The following is a description of a gene set: A process that is carried out at the cellular level which results in the assembly, arrangement of constituent parts, or disassembly of a prolongation or process extending from a neuron, e.g. an axon, or a dendrite. Mouse Gene Set: GOBP_NEURON_PROJECTION_ORGANIZATION studied in species Mus musculus, and this is the list of marker genes: Fcgr2b, Lzts3, Dlg4, Marcks, Grin1, Epha4, Tiam1, Ckap5, Ube3a, Septin7, Caprin1, Cntnap2, Homer1, Xlr4b, Dtnbp1, Arc, Psen1, Cdc42 (NCBI Gene Id 12540), Fyn, Opa1, Epha5, Zdhhc15, Itpka, Ppp1r9a, Chrna7, Igf1r (insulin-like growth factor I receptor), Nlgn3, Tanc1, Map1a (NCBI Gene Id 99114), Abcd2, Dbn1, Ppfia2, Pafah1b1, Mtmr2, Dock10, Lrrk2, Eef2k, Dhx36, Dnm1l, Mfn2, Camk2b, Reln, Hdac6, Itga3, Xlr3b, Apoe, Wnt7a, Abi3bp, Kalrn, Vps35, Dctn1, Actr2, Lrp8, Cdk5, Mfn1, Nedd9, Pak3, Insr, Zfp365, Cux2, Prmt3, Xlr4a (X-linked lymphocyte-regulated 4A), Sipa1l1, Afdn, App, Wasl, Shank1, Arhgap44, Ctnnd2, Kifbp, Abi3, Grin2a, Ephb1, Diaph2, Slc30a1, Zfp804a, Ins2, Shank3, Arhgap33, Il1rapl1, Dip2a, Arf1, Pick1 (NCBI Gene Id 18693), Efna1, Caprin2, Baiap2, Ngef, Abl2, Cdk5r1, Myo5b, Zmynd8, Cask, Ins1, Abhd17b, Pten, Trem2, Actr3, Adcy10, Bhlhb9, Grin2b, Rph3a, Atp1a3, Cttn, Pdlim5, Pls1, Lgmn, Dnm3, Diaph1, Abcd1, Dvl1, Ephb2, Ptprd, Abi2, Kif1a, Dbnl, Stau2, Gsk3b, Ephb3, Cfl1, Prnp, Srcin1, Tanc2, Adam10, Nlgn1